Given this list of marker genes GOLM1, MXD4, NTRK2, CHIT1, PDE3B, RNF213, PRMT8, PSMB11, TG, ESYT2, JAK2, IQCE, PLK3, PPFIA4, ZNF592, KMT2D, UBE2H, MXD1, CLCN4, GRAP2, EPSTI1, MORC3, DNAJC5, SDF2, MPPE1, MTMR10, GMIP, SCAMP3, TTC34, ENO1, SBK1, ETV1, MYO1G, IRAK4, NFAT5, FNTB, LINC01160, IFI27, RASA2 (NCBI Gene Id 5922), SLC17A9, XYLT2, WIPF1, APOC3, TNFRSF1B, OAS2, MCOLN3, NT5DC3, IFNGR2, ARPC5, LRIG1, NSD3, ARHGEF11, SPTBN1, SLC2A8, SHLD1, UGT2A3, RECK, ZHX2, RPH3AL, SOBP, MSN, LFNG, IFI35, RASAL3, ANO1, PAQR7, CCDC88C, MEIS3, PJA1, RAD9A, NBEAL1, SLC28A2, ZMYM5, NRSN2, SPTAN1, DTX1, RAC2, MCTP2, PAQR8, SLCO6A1, SIDT1, RFX4, SH3BP1, TNNT2, PTK2B, PRRG1, CTTNBP2 (NCBI Gene Id 85447), NR4A3, GPR83, RERE (arginine-glutamic acid dipeptide repeats), TRAF1, AP1G2, TMEM62, NLRC3, PTPN22, LYVE1 (lymphatic vessel endothelial hyaluronan receptor 1), NCOR1 (nuclear receptor corepressor 1), SLN (sarcolipin), NEAT1, NFKBIZ, TRAF3, CYTH1, B4GALT1, TMEM123, DOCK2, HELZ2, CORO1A, RTN4RL1, GALNT10, UTRN, EVL, SLC26A6, C19orf12, AMPD1, MADD, ACSS2, RNF14, ADH7, CKB, ST3GAL1, EVA1B, S100A10, UHMK1, GSN, GPR155, EPS15, MARK2, NUCB2, PPM1N, RNF114, KIF1B, TRPM4, TSPAN14, HERC6, DOP1B, PCSK1, TSPAN32, ATXN7L3, LASP1, MALT1, FAM117B, SESN3, ABHD6, SP110, ARRB2, TPST2, SEMA4F, PIK3CD (phosphatidylinositol-4,5-bisphosphate 3-kinase catalytic subunit delta), ASB13, PEA15, SKIL, RAP2B, NES, UBXN11, DGKZ, FAH, FOXP2, CREBBP, ARHGDIB, MTURN, TXNIP, IL21R, TOR1AIP1, SLC20A1, DOK4, CLCNKA, HOPX, PRKD2, FYCO1, ADD1, SSH2, SNX25, TBC1D20, CRHR1 (NCBI Gene Id 1394), LNPEP (NCBI Gene Id 4012), ZNF7, HBP1, CHD7, CYTIP, HCST, SON, WNK1, PLA2G4D, PLCG1, EFEMP2, ENO2, CABIN1, LIMK2, FAM124B, RGS16, PTPRC, ARHGEF3, ITPK1, VAMP1, EML3, ADAMTS10, LY75, POLL, DHX58, TAP1 (transporter 1, ATP binding cassette subfamily B member), here is a description of the gene set: Human Gene Set: GSE31082_DN_VS_CD8_SP_THYMOCYTE_DN from publication Egawa T, Littman DR (PMID 21873191) species: Homo sapiens Mouse thymocytes can be classified into four major subsets based on expression of CD4 and CD8 co-receptors. CD4-CD8- (double negative, DN) cells become CD4+CD8+ (double positive, DP) cells following productive T cell receptor (TCR) beta chain rearrangement. A small proportion of DP cells are selected through interaction of clonal TCRalpha/beta and MHC self peptide complex expressed on thymic stromal cells. DP cell expressing MHC class I-restricted TCR become CD4-CD8+ cells, which will finally differentiate into cytotoxic T cells, while MHC class II restricted selection generates CD4+CD8- helper lineage T cells. We used microarrays to identify genes important for thymocyte differentiation and lineage determination by profiling gene expression in different thymocyte subsets. Genes down-regulated in comparison of CD4- CD8- thymocytes versus CD4- CD8+ thymocytes.